Given this list of marker genes EPHA2, ACVR2A, NOG, HOXA11, BMPR2, MIR150, KLF4, BMPR1A, TP63, ACVR2B, TAF10, TBX3, MSGN1, SSBP3, FGF8, WNT3A, WNT3, JAK2, IKZF3, WNT5A, ARMC5, WLS, PALB2, ACVR1, ZFP36L1, EXT2, SMO, SHH, ITGB1, POU4F1, LEF1, FOXC1, AXIN1, TBX20, TSPY1, YAP1, NCLN, EXT1, FOXC2, BMX, TSPY9 (testis specific protein Y-linked 9), TAL1, HAND1, TBX6, DKK1, MEST, EOMES, SECTM1, MIR145, SMAD2, HES7, ITGB3, MIR1-1, GPI, EYA1, VEGFA, OVOL1, AHDC1, ZFPM2, PRKACA, ITGA2 (NCBI Gene Id 3673), PUS7, TBX19, LHX2, TSPY2, RPL38, SMAD4, FGFR2, ZIC3, APELA, TRIM15, NCKAP1, MESD, TSPY3, ETV2, GDF3, SMAD3, CER1, PAX2, TXNRD1, EPB41L5 (NCBI Gene Id 80242), MESP1, OSR1, POFUT2, DAND5, MESP2, INHBA (inhibin subunit beta A), TSPY8, MIXL1, GDF11, GJA1, FGFR1, BTK, AMH, FOXF1, RPS6KA6, KDM6B, NOMO3, HMGA2, BMP4 (NCBI Gene Id 652), ITGB4, PPP2CA, PRKAR1A, ITGA3, EXOC4, SRF, TEAD2, BMP7, HCK, CRB2, SMAD1, TCF15, DLL3, TBX1, TBXT, NF2, NUP133, EYA2, CTDNEP1, ETS2, NOMO1, FOXH1, IKZF1, WNT11, SCX, GDF1, TSPY10, TIE1, ITGA8, TSPY4, TLX2, SFRP2, LHX1, NR4A3, IRX3, NODAL, POGLUT1, SNAI1, TWSG1 (NCBI Gene Id 57045), CITED2, SIX2, MIR200C, here is a description of the gene set: Human Gene Set: GOBP_MESODERM_DEVELOPMENT The process whose specific outcome is the progression of the mesoderm over time, from its formation to the mature structure. The mesoderm is the middle germ layer that develops into muscle, bone, cartilage, blood and connective tissue. species: Homo sapiens